The following is a description of a gene set: studied in species Homo sapiens Any process that modulates the frequency, rate or extent of calcium ion import into sarcoplasmic reticulum. Human Gene Set: GOBP_REGULATION_OF_CALCIUM_ION_IMPORT_INTO_SARCOPLASMIC_RETICULUM, and this is the list of marker genes: SLN, ATP2A1, PLN, STRIT1, MRLN